The following is a description of a gene set: Genes directly up-regulated by DeltaNp63, the p63 isoform that lacks the canonical transactivation domain and is predominantly expressed in stratifying epithelia, identified through a meta-analysis of both cell lines and primary cells. studied in species Homo sapiens Human Gene Set: RIEGE_DELTANP63_DIRECT_TARGETS_UP from publication Riege K, Kretzmer H, Sahm A, McDade SS, Hoffmann S, Fischer M (PMID 33263276) To identify genes commonly regulated by DeltaNp63 across cell types and tissues, we employed a previously established meta-analysis approach. From 11 genome-wide studies, 16 publicly available gene expression datasets were integrated to generate a specific p63 Expression Score (the number of datasets that identify a gene as significantly up-regulated minus the number of datasets that identify the genes as significantly down-regulated). The gene expression profiling datasets have been obtained from knockdown (n = 12) or overexpression experiments (n = 4) of p63 in primary keratinocytes (n = 3), the keratinocyte cell line HaCaT (n = 2), the foreskin fibroblast cell line BJ (n = 1), the breast epithelial cell line MCF10A (n = 4), the squamous carcinoma cell lines H226 (n = 2), KYSE70 (n = 1), and FaDu (n = 1), as well as the pancreatic ductal adenocarcinoma cell lines BxPC3 (n = 1) and SUIT2 (n = 1) In addition, we integrated 20 p63 ChIP-seq datasets. Given the large number of p63-binding sites identified and the high variance in p63-dependent gene regulation, we employed conservative thresholds to identify high-probability target genes of DeltaNp63. We only used p63-binding sites supported by at least half of the datasets (>=10) that are linked through TSS proximity (within 5 kb) or double-elite enhancer:gene associations to genes with a p63 Expression Score >= 8., and this is the list of marker genes: ARHGAP25, SLC2A9, CDCA4, ASCC3, QSOX2, CARD10, S100A2, SH3PXD2A, PTHLH, MMP14, IRF6, NRG1, PPP4R4, LPAR3, PPFIBP1, NIPAL4 (NCBI Gene Id 348938), YES1, CRKL, COL17A1 (NCBI Gene Id 7828), LIG1, CCNK, TCOF1, PA2G4, RAB38, TSR1, SERPINB13, HRAS, TGFB1, YAP1, FRMD4B, GM2A, SFN, FGFBP1, CSTA, MMRN2, VSNL1, TMEM40, GINS3, SNCA, MAPK6, NRCAM, FLOT2, KREMEN1, STK17A, RGS20, MREG, EHD4, LDLR, SPATS2, FAT2 (FAT atypical cadherin 2), MAPKBP1, CDCA7, NECTIN1, OAS3 (2'-5'-oligoadenylate synthetase 3), PTTG1, RFX7, GSTP1, NDE1, FSCN1, CHAF1A, CDC42SE1, UTP4, NCAPH2, PROCR, NOM1, HMGA2, GNA15, KIRREL1, RNASE7, ARHGDIB, ARHGAP23, ITGA6, WDFY2, PPIF, FABP5, IFI16, ZFP36L2, SSRP1 (structure specific recognition protein 1, NCBI Gene Id 6749), BTBD10, UCK2, NDST1, STX6, TMEM237, ABTB3, DUSP11, CYP27B1, KIF14 (NCBI Gene Id 9928), RAD51C, FOSL1, ERCC6L, SMAD5, FANCI, TOMM34, KIAA0930, HAS3, MAST4, MYO10, XDH, IL4R, MCM3, SMTN, TSPAN5, DUSP6, DUSP7 (dual specificity phosphatase 7), JAG1, LAD1, RAPGEF5, IL1B, MYO19, MALT1, FERMT1, SLC1A5, KIZ, ORC1, RASSF6, MYO5A, GPX2, CCT4, TYMS, SDC1, PAK1, AURKB, CD44, FEZ1, KCTD12, SLC37A2, ILRUN (inflammation and lipid regulator with UBA-like and NBR1-like domains), TRIM7, LRRFIP2, GSDME, TRIP13, BRCA1, HSPA4L, RRP12, ESRP1, DRAP1, INPP1, AK4